The following is a description of a gene set: from publication Chen Y, Wang X (PMID 31504780) Genes predicted to be targets of miRBase v22 microRNA hsa-miR-8089 in miRDB v6.0 with MirTarget v4 prediction scores > 80 (high confidence targets). studied in species Homo sapiens Human Gene Set: MIR8089, and this is the list of marker genes: RARB, FUT11, MTCL2, VTI1A, MAT1A, ABCB9, NUMA1, PCDHGA4, PCDHGA8, HACD3, PCDHGB6, VCF2, CASKIN1, MAT2A, LZTS1, SAMD12, CLDN19, CAPN12, PALM, EGLN3, PCDHGA7, PCDHGA6, CCSER2, CALN1, FAM228B, C17orf107, ELMOD1, TEX36, RANBP1 (RAN binding protein 1), TTF2, PCDHGC4, ABCC10, RGSL1, CELF6, SLC38A7, LYPD3, CIC, ITPRIP (inositol 1,4,5-trisphosphate receptor interacting protein), KCNMA1, ZNF831, TOX3, BCL2L1, RNASE13, LASP1, SNX12 (NCBI Gene Id 29934), AAK1, HSDL1 (NCBI Gene Id 83693), PCDHGA5, DAGLA, PXN, KDELR1, SLC34A2, CARMIL3, SEPTIN5, MBOAT7, FGF19, UBXN4, KSR2, FGF18, CPLX2, PCDHGA1, POPDC3, ZDHHC23, THRA, UNC5B, PCDHGA9, PCDHGB7, NR6A1, PRKCG, NAGA, PSMD5, TSPAN2, TRIM71, CSKMT, LZTS3, PCDHGB5, FOXN3, OSBPL7, FBLN1, SALL1, PPP1CA, MS4A15, VAT1, ITGA5, AKIRIN1, ANKIB1, MAPK1, ENTPD3, SARM1, SLC25A14, ATF6B, SNPH (syntaphilin), PCDHGA10, MLLT6, IQSEC3, SUPT7L, PCDHGB2, PCDHGA2, STX17, LYPD6, APOM, ZNF687, SUSD2, PCDHGB4, GRIP2, SPIB, ZNF559 (zinc finger protein 559), TET3, PPP1R9B, PCDHGB3, NHLH1, DNAJC15, MEIS2, PPP1R1B (NCBI Gene Id 84152), DCTN5, HCCS, FBXO41, LOXHD1, KCNJ10, TJP1, ZNF106, PAK6-AS1, PCDHGA12, VSTM4, ARFIP1, ACACA, LHX3, RNF170, PCDHGC3, EHD3, SOX6, ATXN1L, TSPAN11, PCDHGA11, GFAP, ARL10, NRIP2, SLC17A2, IL6R, PCDHGC5, TEAD1, PCDHGB1, SLC6A9, GAB2, STAM2, MTHFR, GGA3, WDR72, PPP1R10, SRCAP, S1PR2, XPO7, CNGB1, DMWD, GALNT15, POU3F3, ARID3B (AT-rich interaction domain 3B), HEYL, BBIP1, PCDHGA3, CCDC178, SON, MMUT, NAA40, OPRM1, CLSTN1